The following is a description of a gene set: species: Homo sapiens Human Gene Set: GOMF_INSULIN_BINDING Binding to insulin, a polypeptide hormone produced by the islets of Langerhans of the pancreas in mammals, and by the homologous organs of other organisms., and this is the list of marker genes: PIK3R1, INSR, C2CD2L, IGF1R, IDE